Given this list of marker genes OSBPL2, PCLO, CTNNB1, PPFIA3, RIMS1, RIMS3, RIMS2, ERC1, ERC2, CTNNA2, STXBP1, CTBP1, BSN, GUCY1B1, here is a description of the gene set: species: Homo sapiens Human Gene Set: GOCC_PRESYNAPTIC_ACTIVE_ZONE_CYTOPLASMIC_COMPONENT A specialized region below the presynaptic membrane, characterized by electron-dense material, a specialized cytoskeletal matrix and accumulated (associated) synaptic vesicles.